Given this list of marker genes Rps6ka6, here is a description of the gene set: This event has been computationally inferred from an event that has been demonstrated in another species.<p>The inference is based on the homology mapping from PANTHER. Briefly, reactions for which all involved PhysicalEntities (in input, output and catalyst) have a mapped orthologue/paralogue (for complexes at least 75% of components must have a mapping) are inferred to the other species. Reactome Pathway: RSK activation part of: CREB1 phosphorylation through NMDA receptor-mediated activation of RAS signaling studied in species Mus musculus electronically inferred by orthology from the curated human pathway